Given this list of marker genes HYOU1, TNFRSF13C, CORO1A, IKBKG, IRAK4, CASP8, here is a description of the gene set: The inability to synthesize postvaccination antibodies against a pneumococcus antigen, as measured by antibody titer determination following vaccination. studied in species Homo sapiens Complete or near-complete absence of specific antibody response to unconjugated pneumococcus vaccine Human Gene Set: HP_COMPLETE_OR_NEAR_COMPLETE_ABSENCE_OF_SPECIFIC_ANTIBODY_RESPONSE_TO_UNCONJUGATED_PNEUMOCOCCUS_VACCINE